The following is a description of a gene set: Constitutive ablation of the Yin Yang 1 (YY1) transcription factor in mice results in peri-implantation lethality. In this study, we used homologous recombination to generate knockout mice carrying yy1 alleles expressing various amounts of YY1. Phenotypic analysis of yy1 mutant embryos expressing approximately 75%, approximately 50%, and approximately 25% of the normal complement of YY1 identified a dosage-dependent requirement for YY1 during late embryogenesis. Indeed, reduction of YY1 levels impairs embryonic growth and viability in a dose-dependent manner. Analysis of the corresponding mouse embryonic fibroblast cells also revealed a tight correlation between YY1 dosage and cell proliferation, with a complete ablation of YY1 inducing cytokinesis failure and cell cycle arrest. Consistently, RNA interference-mediated inhibition of YY1 in HeLa cells prevents cytokinesis, causes proliferative arrest, and increases cellular sensitivity to various apoptotic agents. Genome-wide expression profiling identified a plethora of YY1 target genes that have been implicated in cell growth, proliferation, cytokinesis, apoptosis, development, and differentiation, suggesting that YY1 coordinates multiple essential biological processes through a complex transcriptional network. These data not only shed new light on the molecular basis for YY1 developmental roles and cellular functions, but also provide insight into the general mechanisms controlling eukaryotic cell proliferation, apoptosis, and differentiation. studied in species Mus musculus Genes down-regulated in MEF cells (embryonic fibroblast) expressing ~25% of YY1. from publication Affar el B, Gay F, Shi Y, Liu H, Huarte M, Wu S, Collins T, Li E, Shi Y (PMID 16611997) Human Gene Set: AFFAR_YY1_TARGETS_DN, and this is the list of marker genes: DLX3 (NCBI Gene Id 1747), RAB3C, FZD3, PIGA, TAC1, PER3, SQLE, ART2BP, IGHM, CEACAM4, SNX5 (NCBI Gene Id 27131), FDPS, NASP, MATN2, SFXN1, HMGB1, RBBP4, PLCB1, ALDH18A1, ANKH, CENPE, SMC2, STMN1, CCNB1, TSPAN8, MTHFD2, HSPB7, BUB1 (BUB1 mitotic checkpoint serine/threonine kinase), PRDX4, TCP1, PRSS29P, PLSCR1, API5 (apoptosis inhibitor 5), CHST2, PRELP, PTPRO, MYO1B, IL1R1, CENPF (NCBI Gene Id 51468), AURKB (NCBI Gene Id 9212), DKK2, SETD1A, TTK, FUS, IFT80, MXD3, LYZ, PTGS1, MAD2L1, NSG1, ELAVL3, COL6A3, BIRC5, HELLS, GPR65, UHRF1 (ubiquitin like with PHD and ring finger domains 1), PTPN2, TNFRSF1B, HMGB3, CHRDL1, CYP3A5, SERPINA1, KIF11, SUV39H2, POF1B, CENPH, SLC22A18, NLRP4, APOC1, SPTBN4, CCNB2, STEAP1 (STEAP family member 1), CCNA2, MCM7, THBS2, HMGCS1, PRC1, SLC25A26, NKX2-3, LIG3, IDI1, NIPSNAP1, AVPR1A, SLC29A1, PLA2G1B, DUT, LRIG1, SOX7, NCAPG, LIN7B, CCL7, FARS2, LMNB1, COL15A1, LHX4, UCP3, HMGB2, TOP2A, EEF1A1, CDC25C, LDLR, SPAG5, TFB1M, TACC3, GPR84, MTNR1A, SOD3, UTS2R, APCDD1, CLCN1, HMMR, TDRD1, STARD4, MRPL19, ABHD3, NT5C1B, SLC35C2, BCAT1, EDNRA (NCBI Gene Id 1909), TERF1, RIPK4, GJB3, TGFBI, IL1RL1, JMJD6, NEURL1, SHCBP1, TRIP13, SEMG1, MSMO1, KIF23, TRIB3 (NCBI Gene Id 57761), RAD51AP1, POLH, DUSP9, FN3K, GATB, CYCTP, SCD, POLA1, NECTIN4, IL1RAPL2, TUBB2A, LUM, ZNF143, LGR5, MCM4, ELOVL6, SCARB1, EXO1, CREB1, CRIP1, HOXD3, GZMA, GNB4, UTY, GREM1, PCDHB12, CHTF18, NR1H4, THY1, DEFB4A, KIF20A, MYCBPAP, FADS2, THBS4, SLC4A4, PLK1 (NCBI Gene Id 5347), RACGAP1, TNFSF11, TMEM45A, ASPM, GALR1, GK2, FGF7, FOLH1, MKI67, PLK4, H3C14, PCOLCE2, LPAR1, CLEC3B, MSH3, PTGDS, SLC25A5, TK1, FCGR2B, CDT1, MRPL52, MCM6, MCM5 (minichromosome maintenance complex component 5), IDH1, OTC, TTF1, AXIN2, CCL2, MSH2, REST, TNNI3, FOXM1, MTCH2, SOCS4, TFAP4 (transcription factor AP-4), HASPIN, PRPS1, UNG, MNDA, HAS2, CENPA, CDC6, MMP13, GFRA1, CDCA3, IGFBP5, SPA17, NSDHL, SPP1, LIG1, ITGA4, RAD18, MCM3, RFC4, GJD2-DT, SLC4A10, FBXW12, DIAPH3, CXCL6, HLA-B, SFTPC (surfactant protein C), CYP51A1, VN1R17P (vomeronasal 1 receptor 17 pseudogene), PDGFRA, FEN1, FMOD, STEAP4, PRKG2 (protein kinase cGMP-dependent 2), AURKA, MCHR1, FDFT1, CCN5, FABP9, ALOX15B, CYP7B1, B3GAT3, KHDRBS1, LEP, TGFBR1, PFDN5, CRABP1, DHCR24, BUB1B, VAV1, DNAJC2, RAB27A, KIF22, ANP32E, RPS6KA4, KIF2C, DKK3, GZMH, ATP6V1E1